Given this list of marker genes Apoa2, Hnf1a, Ces1a, Apom, Ces1h, Ces1c, Abca5, Ces1f, Lipg, Ces1b, Ces1d, Abca1, Scarb1, Abcg1, Apoe, Lcat, Apoa1, Ces1e, Ces1g, Apoa4, here is a description of the gene set: The directed movement of peripheral cell cholesterol, cholest-5-en-3-beta-ol, towards the liver for catabolism. species: Mus musculus Mouse Gene Set: GOBP_REVERSE_CHOLESTEROL_TRANSPORT